The following is a description of a gene set: species: Mus musculus Mouse Gene Set: GOCC_IGA_IMMUNOGLOBULIN_COMPLEX A protein complex composed of two identical immunoglobulin heavy chains of the IgA isotype and two identical immunoglobulin light chains, held together by disulfide bonds, and sometimes complexed with J chain or J chain and secretory component. An IgA immunoglobulin complex may be embedded in the plasma membrane or present in the extracellular space, in mucosal areas or other tissues, or circulating in the blood or lymph., and this is the list of marker genes: Igkv3-7, Igkv3-3, Igkv3-9, Igkv3-5, Igkv3-12, Igkv3-10, Igkv3-1, Jchain, Igkv3-4, Igha, Pigr, Igkv18-36, Igkv3-2